The following is a description of a gene set: Abnormal pulmonary valve morphology studied in species Homo sapiens Any structural abnormality of the pulmonary valve. Human Gene Set: HP_ABNORMAL_PULMONARY_VALVE_MORPHOLOGY, and this is the list of marker genes: DLL4, SNX10, NRAS, COMT, NOTCH1, SPRED2, NXN, KRAS, RAF1, RRAS (NCBI Gene Id 6237), ARHGAP31, SALL1, EOGT, RNF135, B3GLCT, TGFBR1, ZNF699, RBPJ, DYRK1A, PTPN11, RASA2, DOCK6, KIF7, IDS (iduronate 2-sulfatase, NCBI Gene Id 3423), BRAF, ARVCF, SOS1, TCIRG1, DACT1, DDX3X, CLCN7, TMEM70, FLT4 (fms related receptor tyrosine kinase 4), PRKAR1A, CBL, TBX1, POLR3A, HIRA, RREB1, TGFBR2, ROR2, ZEB2, SEC24C, GP1BB, RIT1, TNFSF11, UFD1, SMAD2, MRAS, ATRX, LZTR1, SOS2, POLA1, RRAS2, FOXF1 (forkhead box F1), JMJD1C, PIGL, KAT5